The following is a description of a gene set: Acetylcholine is the neurotransmitter found at neuromuscular junctions, synapses in the ganglia of the visceral motor system, and at a variety of sites within the central nervous system. A great deal is known about the function of cholinergic transmission at the neuromuscular junction and at ganglionic synapses, the actions of ACh in the central nervous system are not as well understood. Acetylcholine is synthesized in nerve terminals from acetyl coenzyme A (acetyl CoA) synthesized from glucose) and choline. This reaction is catalyzed by choline acetyltransferase (ChAT). The presence of acetyltransferase in a neuron is thus a strong indication that ACh is used as one of its transmitters. Choline is present in plasma at a concentration of about 10 mM, and is taken up into cholinergic neurons by a high affinity Na+/choline transporter. About 10,000 molecules of ACh are packaged into each neurotransmitter containing vesicle by a vesicular ACh transporter.<br> Nicotinic acetylcholine receptors (nAchR) are ionotropic receptors that can be activated by nicotine and permeable to of monovalent (sodium, potassium) and divalent cations(calcium), however, the permeability of sodium and/or calcium maybe high or low depending on the subunit composition of the receptor. Nicotinic acetylcholine receptors are expressed widely in the central and peripheral nervous system in the presynaptic terminal, terminal bouton and post synaptic neuron. Functionally nicotinic acetylcholine receptors in the pre synaptic and postsynaptic terminals behave similarly. Nicotinic AChR are a family of acetylcholine gated pentameric receptors that are formed by the association of various combinations of mostly alpha, beta subunits (for the neuronal type) and together with gamma, delta and epsilon subunits (for the muscle type). In addition, receptors may be more diverse due the fact that some receptors have same subunits but the stoichiometry of the subunits is different. part of: Neurotransmitter receptors and postsynaptic signal transmission Reactome Pathway: Acetylcholine binding and downstream events studied in species Homo sapiens, and this is the list of marker genes: CHRNB3, CHRNB2, CHRNA4, CHRNE, CHRNB4, CHRNA7 (NCBI Gene Id 1139), CHRNA5, CHRNG, CHRNA6, CHRND, CHRNA1, CHRNA3, CHRNA2, CHRNA9